The following is a description of a gene set: Mammary gland development: puberty - stage 2 of 4 Human Gene Set: WP_MAMMARY_GLAND_DEVELOPMENT_PUBERTY_STAGE_2_OF_4 studied in species Homo sapiens, and this is the list of marker genes: CCND1, ESR1, STAT5A, MYC, PGR, EGF, VIM, NRIP1, FOSL1, AREG, TIMP1, FN1, ERBB2